Given this list of marker genes HIBCH, ACOX1, GSTZ1, ACSL4, CA6, FABP2, ADSL, GAPDHS, TDO2, ENO2, IDH3G, ACAA1, GPD2, ALAD, KMT5A, NBN, DECR1, CD1D, ACAT2, ACSS1, RETSAT, IDH1, ACOT8, PSME1, RDH16, UROS, CA4, BCKDHB (NCBI Gene Id 594), ACOT2, LGALS1, PTS, ACADL, LTC4S (NCBI Gene Id 4056), ALDH3A2, ALDH9A1, ACADM, EPHX1, GCDH, HSD17B11, HMGCL, UBE2L6, PDHB, LDHA, CRYZ, ALDOA, ACADVL, UROD, AOC3, APEX1 (apurinic/apyrimidinic endodeoxyribonuclease 1), ALDH1A1, MIF, PTPRG, CRAT, RDH11, HMGCS2, ME1, ADH1C, PCBD1, ECI2, S100A10, EHHADH, DLD, HSD17B10, ETFDH, ECI1, UGDH, FABP1, HSP90AA1, HAO2, ADH7, AQP7 (aquaporin 7), NTHL1, HADH, PRDX6, GABARAPL1, AADAT, SUCLG2, CPOX, ACADS, IDI1, HCCS, SDHA, ELOVL5, HSD17B4, CD36 (NCBI Gene Id 948), HADHB, MLYCD, YWHAH, FMO1, SDHC, CYP4A22, SUCLA2, ECHS1, MIX23, SMS, ECH1, CYP1A1, PDHA1, VNN1, FH (fumarate hydratase), ALDH3A1, ODC1, HMGCS1, REEP6, BLVRA, ACAA2, ENO3, HSD17B7 (NCBI Gene Id 63064), CBR3, SDHD (succinate dehydrogenase complex subunit D), SUCLG1, NCAPH2, GLUL, MDH2, MDH1 (NCBI Gene Id 4190), NSDHL, CBR1, IDH3B, CEL, OSTC, ADIPOR2 (NCBI Gene Id 84751), G0S2, MCEE, D2HGDH, ACO2, CYP4A11, GPD1, HPGD, DLST, XIST, HSPH1, SLC22A5, AUH, PPARA, FASN, ERP29 (NCBI Gene Id 10961), ACSL5, H2AZ1, ACSL1, DHCR24, CPT2, RAP1GDS1, BMPR1B, ACSM3, CPT1A, HSDL2, METAP1, MAOA, GAD2, BPHL, GRHPR, IL4I1 (interleukin 4 induced 1), CIDEA (NCBI Gene Id 1149), CA2, SERINC1, MGLL, INMT, TP53INP2, here is a description of the gene set: studied in species Homo sapiens Human Gene Set: HALLMARK_FATTY_ACID_METABOLISM Genes encoding proteins involved in metabolism of fatty acids. from publication Liberzon A, Birger C, Thorvaldsdóttir H, Ghandi M, Mesirov JP, Tamayo P (PMID 26771021)